Given this list of marker genes LILRA4, F3, MMRN2, PDGFD, SQSTM1, LRCH4, RFTN1 (NCBI Gene Id 23180), RIOK3, VEGFC, TMSB4X, IRAK3, IFNK, TAC1, CCL1, ANKRD17, GSDMD, NR1D1, APP, P2RY12, NINJ1, RPS19, NCR3, TKFC, TLR3, CCR1, XCL1, ZBP1, CEBPA, ECSIT, GPRC5B, CXCL17, CCL5, PJA2, VAV1, MIR210, MATR3, REG3G, THBS1, VAMP8, HPX, AURKB, ESR1, CCR2, MIR22, LAG3, CASP4, MIR128-1, UFD1, AP3B1, IFI35, TNFAIP3, SPI1, NAGLU, LRRK2, GPS2, STX4, XRCC6, RAB11FIP2, CD36, TRIM32, PDCD4, SLC15A2, CD28 (CD28 molecule), HDAC6, SERPINF2, CXCL8, CAV1, KLRK1, STAT5A, IRAK1, WNT5A, DEFB131A, FCN1, CCDC134, COLEC10, CD1D, LPAR1, FCER1G, PPP2CA, MIR21, SLIT2, TRIM5, RNF170, IL2, NUPR1, NR1H4, CNTF, LRRC14, PRKCA, PLAU, LILRA2, NLRX1 (NLR family member X1), FCGR1A, CSF1R, CEBPB, OAS3 (2'-5'-oligoadenylate synthetase 3), PTGS2, C2CD4A, PDE2A (NCBI Gene Id 5138), UNC93B1, FABP4, GDI1, MAPKAPK3, MNDA, LSM14A, NLRP6, HCK, POLR3D, CX3CR1, RIPK1, BMPR2, PTPN22, CAMK2N1, PAK2, WASHC4, CCN4, ZDHHC3, TNF, ARRB2, MAP3K8, TNIP3, POLR3C, POLR3B, CTTN, IL18RAP, HAVCR2, TAB1, MIR181B1, CD274, RNF115, PIK3CG, ZDHHC4, FBXL2, FLOT1, KAT5, TIFA, CADM1, HSPD1, ARG1, C5AR1 (NCBI Gene Id 728), PRKD2, RASGRP1, AGT, BECN1, S100A7, NPLOC4, P2RX4, CSF1, PARP1, PIK3AP1, IRAK4, NLRP10, CD47, KLK7, IL18, CPTP, ACOD1, CD300LF, GBP2, GBP3, LRSAM1, CASP12, CD180, CASP6, CRTAM, NFKBIL1, EREG, ABHD8, SEMA5A, CLPB, THBS4, TSPAN6, IL15, CMKLR1, NOP53, KIR2DL4, IL23A, MDK, CLOCK, VAMP7, ZDHHC9, LYPLAL1, MAPK3, IL16, HMGB1, KLRC4, NOD2, FEM1A, CASP3, LGALS1, SPSB3, CCR6, P2RX7, TMEM102, C3AR1, HSP90B1, MOSPD2, NFKBIA, PGC, LBP, IFNB1, PLAT, NLRP1, PTGER3, IRGM, IL1RL1, MEFV, RAB7B, APPL2 (adaptor protein, phosphotyrosine interacting with PH domain and leucine zipper 2), PTN, TNIP2, LACC1, FGF16, NECTIN2, TASL, MIR520E, SMPDL3B, MIR20A, RNF135, PTGER4, DNM1L, HSPA8, MED1, ABCC1, TTBK1 (tau tubulin kinase 1), HTR2A, MIR142, CLEC7A, POLR3F, TLR10, TNFSF14, STAP1, PSPC1, LY86, TRPV4, STAT5B, DAPK2, IL6, SLC15A3, FCN2, CYBA, SCG2, MET, CD160, NLRP3, MAVS, DDX3X (DEAD-box helicase 3 X-linked), NONO, CACTIN, NEAT1, TMEM126A, SEC14L1, NLRP2B, AKIRIN1, PYDC2, ZNRF4 (NCBI Gene Id 148066), NLRC3, USP17L2, C2CD4B, TLR4, SNX4, IL12B (interleukin 12B), MFHAS1, CASR (NCBI Gene Id 846), CASP5, IKBKE, NFKBIZ (NFKB inhibitor zeta), TBK1, RIPOR2, HSP90AA1, ETS1, SMOC2, CCR7, SH2D1B, IPO5, F7, LPL, WNK1, TLR8, TRIM56, LDLR, PTK2, GFI1, PLG, IRAK2, MIR206 (NCBI Gene Id 406989, microRNA 206), CREB3L3, PDGFRA, BIRC3, PYDC1, RASGRP4, MIR92A1, MCU, CD300A, PPP6C, HSPA1B (NCBI Gene Id 3304), OTUD4, CARD8, LGALS2, CAMK1D, PYDC5, FFAR2, NLRC5, IFI16, CALR, MIR19A, LAMP2, RSAD2, TRAF6, COLEC11, IL17F, PRKCE, SCARA3, SASH1, MIR4691, PPT1, CCL26, DDX41, S100A9, IFNG, ERBIN, RAET1E, CCL7, CCL3, FPR2, CX3CL1, TRIM6, IRF5, PVR, APPL1, SCIMP, TLR1, TLR9, FGF2, ZCCHC3, AZU1, TLR2, ZC3HAV1, ANO6, IL12A, EDN3, FCN3, HLA-E, ZNFX1, HLA-F, TRAF3, EDN1, CHUK, TRIM62, FADD, ADORA2B, TRADD, PHB2, ALPK1, APOH, XIAP, S1PR1, PQBP1, MIR17, TPBG, MAPK8, CD81, HEXIM1, CASP1, PARP9, USF1, GPSM3, PYCARD, BRAF, LGALS9, TLR5, TRIM65, TREM2, DHX9, RTN4, CLEC6A, TOMM70, NRP1, MIF (NCBI Gene Id 4282), SRC, SERPINE1, THBD, YWHAE, SMAD3, LRRC19, MMP12, AP1G1, KLK3, TNFSF11, OTULIN, RAC2 (NCBI Gene Id 5880), FCRL3, LETMD1, HSPB1, MIR144, GBP5, KCNJ8, HRG, IFIH1, GKN2, IDO1, CXCL13, CLEC4E, TRIM3, KLRC4-KLRK1, EDN2 (NCBI Gene Id 1907), MIR431, EP300, AKT1, MGST2, RNF144A, SH2D1A, TNFSF18, SFPQ, CPT1A, ATAT1 (NCBI Gene Id 79969), TRAF3IP3, MIR146A, NAGK, IL6ST, TXK, RNF34, UBE2K, DDT, TNFRSF1A, OPTN, SLAMF1, MIR200B, VEGFD, IL21, KLRD1, CLNK, CCL21, PTPN11, MARK4, GPR4, KLRC2, ITGA2, NAIP, MIR149, TREML4, KDR, OSMR, PDGFB, TGFB1, C1QBP, RIPK2, USP15, TREX1, F2RL1, EMILIN2, IRF1, TLR7, IL6R, UBQLN1, FOSL1, USP29, RELA, SNCA, PUM2, ADAM17, LATS2, CD226, CCL4, TNIP1, MYD88, AGER (NCBI Gene Id 177), S100A12, COLEC12, WDFY1, TNFSF4, EIF2AK2, KIR2DS2, HYAL2, CREBBP, F2, ZNF580, FGF10, SLC19A1, ZP3 (zona pellucida glycoprotein 3), PTK2B, SCARF1, TSLP, CD74, GPR108, USP50, POMC, ABHD17A, STMP1, MAP2K6, MIR708, C3, TRIM41, PDPK1, MAP3K7, PERP, DSCAM, TYRO3, PDGFRB, RAC1, AIM2, MIR126, PLA2G5, IL17RA, SIGLEC16, SETD4, RNF39, OAS1 (NCBI Gene Id 4938), ARTN, MAPKAPK2, HLA-G, MIR222, DDX60, MAPK13, CTSC, NTRK3, RNF185, MAPK1, CCL24, IRF4, STK39 (serine/threonine kinase 39), HCFC2, SMPDL3A, VEGFB, DHX58, AARS2, TLR6, ZDHHC18, LGMN, MIR200C, XRCC5, BMP6 (NCBI Gene Id 7964), NCKAP1L, PLSCR1, SIN3A, TNFRSF11A, CARD9, SLC46A2, BANF1, MMP8, PUM1, LAMP1, RBM14, TRIM25, PLCG2, RARRES2, TRIM31, TIRAP, PAK3, PGF, NR1H3, DAB2IP, CCL2, RNF125, AIF1, BCL10, OXSR1, PTPRS, HMGB2, VTN, PCBP2, NTF3, KLK5, TAX1BP1, S100A8 (NCBI Gene Id 6279), GRAMD4, PYHIN1, DEFB124, NPY5R, LGR4, CXCL12, CREB3, MIR520B, BTK, GAS6, PPM1F, NOD1, KCNK6, ADAM8, RNF31, PIK3R1, LTA, MIR140, USP27X, TICAM1, GRN, ZDHHC5, SYK, SUCNR1, TAFA3, NKG7, IKBKB, PAK1, S100A14, NEDD9, LTF, KLRC3, CXCL10, ITCH, NAPEPLD, TRIM11, PHB1, PLA2G7, IRF3 (interferon regulatory factor 3), SWAP70, KCNK13, MARCHF5, CSNK1A1, SLAMF6, TARBP2, PLA2G3, IL17RB, TICAM2, BPIFB1, SIRT2, TIFAB, PLA2G2A, STX3, DHX33 (DEAH-box helicase 33), LATS1, IL33, ELP6, CDH13, IL34, CTSS, SLC15A4, TRIM15, AKIRIN2, GPATCH3 (G-patch domain containing 3), RIGI, GBP1, IL1B, TYROBP, RBM47, LYN, FYN, AGTR1 (angiotensin II receptor type 1), CYLD, HSPA1A, STING1, CD14, LILRA5, OGT, CXCR3, RAET1G, DEFB114, RPS6KA3, TRIL, FLOT2, ADAM10, SARM1, IL17A, PTPRJ, ZNRF1, FFAR3, CCL19, NLRP12 (NLR family pyrin domain containing 12), MSTN, OASL, LY96, PARK7, INAVA, PRKDC, OSM, ZDHHC1, VEGFA, KARS1, PELI1, FGFR1 (NCBI Gene Id 84151), NLRC4, POLR3G, EMILIN1, KLRC1 (killer cell lectin like receptor C1, NCBI Gene Id 3821), MBL2, MIR221 (NCBI Gene Id 407006), ZDHHC12, BRCC3, MEGF8, NMI, FGF18, IRF7, PRKD1, BIRC2, CGAS, NEK7, EPG5, here is a description of the gene set: Human Gene Set: GOBP_POSITIVE_REGULATION_OF_RESPONSE_TO_EXTERNAL_STIMULUS studied in species Homo sapiens Any process that activates, maintains or increases the rate of a response to an external stimulus.